The following is a description of a gene set: Human Gene Set: GOBP_ATRIAL_CARDIAC_MUSCLE_CELL_MEMBRANE_REPOLARIZATION studied in species Homo sapiens The process in which ions are transported across the plasma membrane of an atrial cardiac muscle cell such that the membrane potential changes in the repolarizing direction, toward the steady state potential. For example, the repolarization during an action potential is from a positive membrane potential towards a negative resting potential., and this is the list of marker genes: FLNA, KCNN2, MIR328, CACNA1D, KCNJ3, KCNE5, NPPA, KCNJ5, KCNA5, KCNQ1, SCN5A